The following is a description of a gene set: species: Homo sapiens Transcription in eukaryotes is a tightly regulated, multistep process. Gene-specific transcriptional activators, several different co-activators and general transcription factors are necessary to access specific loci to allow precise initiation of RNA polymerase II transcription. As the dense chromatin folding of the genome does not allow the access of these sites by the huge multiprotein transcription machinery, remodelling is required to loosen up the chromatin structure for successful transcription initiation. In the present review, we summarize the recent evolution of our understanding of the function of two histone acetyl transferases (ATs) from metazoan organisms: GCN5 and PCAF. Their overall structure and the multiprotein complexes in which they are carrying out their activities are discussed. Metazoan GCN5 and PCAF are subunits of at least two types of multiprotein complexes, one having a molecular weight of 2 MDa (SPT3-TAF9-GCN5 acetyl transferase/TATA binding protein (TBP)-free-TAF complex/PCAF complexes) and a second type with about a size of 700 kDa (ATAC complex). These complexes possess global histone acetylation activity and locus-specific co-activator functions together with AT activity on non-histone substrates. Thus, their biological functions cover a wide range of tasks and render them indispensable for the normal function of cells. That deregulation of the global and/or specific AT activities of these complexes leads to the cancerous transformation of the cells highlights their importance in cellular processes. The possible effects of GCN5 and PCAF in tumorigenesis are also discussed. from publication Nagy Z, Tora L (PMID 17694077) Human Gene Set: NAGY_PCAF_COMPONENTS_HUMAN Composition of the 2 MDa human PCAF complex., and this is the list of marker genes: KAT2B (lysine acetyltransferase 2B), TAF5L, TAF10, SUPT3H (NCBI Gene Id 8464), TAF6L, TAF12, TADA3, TRRAP, TAF9